Given this list of marker genes Ube2j2, Fabp5 (fatty acid binding protein 5, epidermal), Lcp1, Casp6, Pim1, Slc30a4, Wdfy4, Adam8, Efhd2, Jak2, Gfra2, Kynu, Rnf19b, Slc14a1, here is a description of the gene set: studied in species Mus musculus from publication Cui A, Huang T, Li S, Ma A, Pérez JL, Sander C, Keskin DB, Wu CJ, Fraenkel E, Hacohen N (PMID 38057668) Cytokines mediate cell-cell communication in the immune system and represent important therapeutic targets. A myriad of studies have highlighted their central role in immune function, yet we lack a global view of the cellular responses of each immune cell type to each cytokine. To address this gap, the authors created the Immune Dictionary, a compendium of single-cell transcriptomic profiles of more than 17 immune cell types in response to each of 86 cytokines (>1,400 cytokine-cell type combinations) in mouse lymph nodes in vivo. A cytokine-centric view of the dictionary revealed that most cytokines induce highly cell-type-specific responses. For example, the inflammatory cytokine interleukin-1β induces distinct gene programmes in almost every cell type. A cell-type-centric view of the dictionary identified more than 66 cytokine-driven cellular polarization states across immune cell types, including previously uncharacterized states such as an interleukin-18-induced polyfunctional natural killer cell state. Mouse Gene Set: CUI_CDC2_IL17E_RESPONSE_UP Genes positively differentially expressed in cell type: cDC2 (conventional dendritic cell type 2) upon treatment with cytokine: IL-17E in mouse lymph nodes in vivo.